The following is a description of a gene set: Human Gene Set: GOBP_PROTEIN_FOLDING_IN_ENDOPLASMIC_RETICULUM A protein folding process that takes place in the endoplasmic reticulum (ER). Secreted, plasma membrane and organelle proteins are folded in the ER, assisted by chaperones and foldases (protein disulphide isomerases), and additional factors required for optimal folding (ATP, Ca2+ and an oxidizing environment to allow disulfide bond formation). studied in species Homo sapiens, and this is the list of marker genes: P4HB, PDIA3, DNAJC10, DNAJC3, CANX, VAPA, ERO1A, PDIA2, ERO1B, CALR, HSP90B1, HSPA5 (NCBI Gene Id 3309)